The following is a description of a gene set: Human Gene Set: MODULE_350 studied in species Homo sapiens Genes in the cancer module 350., and this is the list of marker genes: SREBF1, RNF126, POLR2E, FAM89B, HBB, EWSR1, FAHD2A, APBA3 (NCBI Gene Id 9546), TTTY6, DYNC2I2, TRIM27, CCDC148, FOXM1, RNF7, SERPINB3, RPRD1B, TMEM63B, CTSL, F11R, MRPS12, SURF1, SDC2, FXYD3, MON1B, DXO, MRPL4, NUCB1, SF1, RAB24, SNW1, ABCA3, PLEKHH3, ITPKC, ECI1, LAPTM4B, MCRIP2, PLOD2, TSPAN4, NR1H2, TMEM134, BTG1, LTBP2, TMED3, ZMPSTE24, DNMBP, SULT1A2, MRPL46 (mitochondrial ribosomal protein L46), RHBDD3, PLD3, ARSA, RNF181, CLPTM1, SNRNP70, EIF2S1, TAF6, SBF1 (NCBI Gene Id 6305, SET binding factor 1), DYRK1A, BAG6, EFNB1